The following is a description of a gene set: Any process that activates or increases the frequency, rate or extent of corticosteroid hormone secretion. species: Mus musculus Mouse Gene Set: GOBP_POSITIVE_REGULATION_OF_CORTICOSTEROID_HORMONE_SECRETION, and this is the list of marker genes: Ecrg4, C1qtnf1 (C1q and tumor necrosis factor related protein 1), Galr1, Gal, Dab2, Ghrl, Bmp6, Crh, Tac1